The following is a description of a gene set: Mouse Gene Set: GOCC_PHAGOCYTIC_VESICLE_MEMBRANE species: Mus musculus The lipid bilayer surrounding a phagocytic vesicle., and this is the list of marker genes: Tap1, H2-Q7, Lamp2, Tlr6, Slc15a2, Rab20, Rab11fip1, Rab11b, Rab10, Slc9a9, Rab32, Pikfyve, Rab8a, Rab5a, Syt7, Anxa3, Lamp1, Rab7b, Pip4p1, Rab38, Rab31, Pfpl (NCBI Gene Id 56093), H2-D1, Rab23, Rab9, Ocrl, Rab8b, Mpeg1, Rab39, Mtmr4, Irgm1, B2m, H2-T23, Rapgef1, Tlr1, Tapbp, Pip4p2, Dmbt1, Rab34, Appl2, Rab43, Rab22a, H2-T3, Rab9b, Slc48a1 (NCBI Gene Id 67739), Clec4e, Sec61a1, Dnm2, Slc11a1, Coro1a, Tlr2 (NCBI Gene Id 24088), Rab7, Mcoln1, Rilp, Tcirg1, Inpp5b, H2-Q10, Hvcn1, H2-K1